The following is a description of a gene set: species: Homo sapiens Cytotoxic T lymphocyte antigen-4 (CTLA-4) is an immune checkpoint molecule predominantly expressed on the surface of activated T cells and regulatory T (Treg) cells. It plays a critical role in inhibiting T-cell activation and maintaining immune homeostasis. After acctivation of T lymphocytes through their antigen receptor (TCR) induces the upregulation of CTLA-4 expression. CTLA-4 engagement alongside TCR activation inhibits T cell responses through two primary mechanisms: competing with CD28 for B7 binding to reduce costimulation, and delivering a negative signal directly into the T cells. It has been reported that phosphotyrosine-dependent recruitment of the SHP-2 phosphatase to CTLA-4 inhibits T cell activation and expansion by dephosphorylation of CD3/TCR chains. <br>CTLA-4 inhibits T cell activation through several mechanisms, including the reduction of IL-2 production and expression, as well as by arresting T cells in the G1 phase of the cell cycle. This checkpoint molecule not only impacts the T cells that express it but also exerts a dominant regulatory influence on the proliferation of other T cells. This ability to limit the proliferation of surrounding T cells is crucial in preventing autoreactivity and maintaining immune tolerance, ensuring that the immune system does not inadvertently target the body's own tissues. <br>Due to its ability to modulate immune responses, CTLA-4 has emerged as a significant therapeutic target for managing conditions such as cancer, autoimmune diseases, and transplant rejection. part of: Regulation of T cell activation by CD28 family Reactome Pathway: Co-inhibition by CTLA4, and this is the list of marker genes: AKT1, CTLA4, PPP2R5D, LCK, SRC, FYN, LYN, CD86, PTPN11, PPP2R1A, PPP2R5A, PPP2CB, AKT2, YES1, PPP2CA, CD80 (CD80 molecule), PPP2R1B, AKT3, PPP2R5B, PPP2R5E, PPP2R5C